Given this list of marker genes Adra1d, Gabbr1, Adra1a, Gabbr2, Adra1b, here is a description of the gene set: Mouse Gene Set: GOBP_NEURON_GLIAL_CELL_SIGNALING species: Mus musculus Cell-cell signaling that mediates the transfer of information from a neuron to a glial cell. This signaling has been shown to be mediated by various molecules released by different types of neurons, e.g. glutamate, gamma-amino butyric acid (GABA), noradrenaline, acetylcholine, dopamine and adenosine.